Given this list of marker genes DEFB127, DEFB105A, DEFB124, DEFB131A, DEFB104A, DEFB130B, DEFB4A, DEFB110, DEFB118, TLR1, DEFB103B, TLR2, DEFB106B, DEFB109B, DEFB134, DEFB125, DEFB136 (NCBI Gene Id 613210), DEFB108B, DEFB126, DEFB135, DEFB116, CCR2, DEFB113, CCR6, DEFB132, DEFB130A, DEFB133, DEFB1, DEFB107B, DEFB4B, DEFB123, DEFB121, DEFB105B, DEFB115, DEFB107A, DEFB103A, DEFB129, DEFB112, DEFB128, DEFB119, DEFB106A, DEFB104B, DEFB114, here is a description of the gene set: Beta defensins Human Gene Set: REACTOME_BETA_DEFENSINS species: Homo sapiens